Given this list of marker genes Timp4, Wwp2, Ly6e, Rgcc, Ccl2, Itgb5, St3gal5, Angptl4, Rnf19b, Ccl7, Rdh10, Masp1 (NCBI Gene Id 17174), Khk, Cyp1b1, Tmem268, Cdk18 (cyclin dependent kinase 18), Ugcg, Slc40a1, Sertad4, Gpr15lg, Ncam1, here is a description of the gene set: studied in species Mus musculus from publication Wotton S, Terry A, Kilbey A, Jenkins A, Herzyk P, Cameron E, Neil JC (PMID 18560354) Mouse Gene Set: WOTTON_RUNX_TARGETS_UP The Runx genes are important in development and cancer, where they can act either as oncogenes or tumour suppressors. We compared the effects of ectopic Runx expression in established fibroblasts, where all three genes produce an indistinguishable phenotype entailing epithelioid morphology and increased cell survival under stress conditions. Gene array analysis revealed a strongly overlapping transcriptional signature, with no examples of opposing regulation of the same target gene. A common set of 50 highly regulated genes was identified after further filtering on regulation by inducible RUNX1-ER. This set revealed a strong bias toward genes with annotated roles in cancer and development, and a preponderance of targets encoding extracellular or surface proteins, reflecting the marked effects of Runx on cell adhesion. Furthermore, in silico prediction of resistance to glucocorticoid growth inhibition was confirmed in fibroblasts and lymphoid cells expressing ectopic Runx. The effects of fibroblast expression of common RUNX1 fusion oncoproteins (RUNX1-ETO, TEL-RUNX1 and CBFB-MYH11) were also tested. Although two direct Runx activation target genes were repressed (Ncam1 and Rgc32), the fusion proteins appeared to disrupt the regulation of downregulated targets (Cebpd, Id2 and Rgs2) rather than impose constitutive repression. These results elucidate the oncogenic potential of the Runx family and reveal novel targets for therapeutic inhibition. Common target genes up-regulated by all three Runx family members (RUNX1, RUNX2, and RUNX3) in MEF cells (embryonic fibroblasts).